Given this list of marker genes IFNG, CDKN1B, ELMO2, REST, KCNH1, ANTXR2, KCNN3, CDKN2C, FAM20C, TSC1, ATP6V1B2, SOS1, MEN1, FAM20A, TSC2, ABCA5, NOTCH3, CDKN2B, CDKN1A, PDGFRB, DHCR24, here is a description of the gene set: species: Homo sapiens Gingival fibromatosis The presence of fibrosis of the gingiva. Human Gene Set: HP_GINGIVAL_FIBROMATOSIS